Given this list of marker genes MTMR6, MFSD2A, ETF1, LINC00620, RCBTB2, WRN, SMAD9, SUB1, HASPIN, TNF, KCNJ10, GMNN, TMEM170A (transmembrane protein 170A), KCNQ3, AMOT, CNOT6L, OLFM1, ZNF366, RABL3, PTCHD3P1, SCUBE1, DMKN, RPS16P5, CDY1 (chromodomain Y-linked 1), SLC38A3, VSTM2A-OT1, C8orf34, PNPLA8, ZNF22-AS1, CASS4, PRDM5, DYNC2H1, BHLHE40, CXCL1, ZNF404, CREBRF, IL17D, IFNG, AEBP2, CDR1, CUL1, ZNF540, C15orf48, KIF16B (NCBI Gene Id 79757), FAM199X, ATG5, MN1, KPNA3, GABARAPL1, DCTN4, KRT76, TUBA1A, TBC1D15, MBIP, CFAP20, TEAD1, SNX4, TGIF2 (NCBI Gene Id 60436), ZBTB8A, CDH24, DDX51, RRP15, SLAIN1, WDR33 (WD repeat domain 33), FNDC8, CCKAR, AKAP9, BACE2, HSPA9, KIAA1586 (NCBI Gene Id 57691), ECSCR, RNASE3, ADRA2B, LRRC4B, MIR100HG, PDHX, SERPING1, ADGRB1, ZNF781, SELE, ASF1A, PRR22, PHLDA1, ENTPD1-AS1, ECE2, LINC00656, MEIG1, GPSM1, ARHGEF10L, PEG10, ESCO1, TOMM70, LPAL2, PSME4, RASGEF1B, OBP2B, NUDT11, EOLA2, FGF1, MNT, CAMK2A, TECRL, IFT20, WDFY1, KPNA5, CAPN14, YPEL5, PI3, EBLN2, UBQLN1, DTNB, LINC00226 (long intergenic non-protein coding RNA 226), ZNF292, ZNF569, CHORDC1, ZNF644, SPATA6L, PCDHB6, TFAM, ATP8A2, CCNF, NUP98, UBC, CAND2, CCNH, CCL20, THBD, CMSS1, PICART1, BCLAF1, CRY1, ZACN, KLHL34, MMP20, EREG, RNF38 (ring finger protein 38), TMEM9B, LRATD1, PPP2CA, SPAG6, CASD1, PROM1, KIAA0087, LAPTM4A, FBXO10, SPATA12, ROPN1, LYSMD3, DCAF4L1, PCDHB4, RBM15, TNFAIP6 (TNF alpha induced protein 6), CARMIL1, MYEF2, CEACAM8, MAP3K2, DUSP10, EEA1, VPS11, CRISP3 (NCBI Gene Id 10321), FBXO30, TNFRSF10C, APOM (NCBI Gene Id 55937), ANGPTL1, LIMK2, PSMB1, GALNT3, LRRC34, DBR1, WBP4, NDEL1, CYP4F3, NEFL, SNW1, NUDT13, CTNNB1, CAMP, MTERF4, PC, PIAS4, SEPTIN7P2, RIC3, ERVW-1, LINC00922, DIO2, CCDC43, TIMD4, LINC01354, SPMIP3, SPRY2, SMTNL1, here is a description of the gene set: studied in species Homo sapiens Human Gene Set: GSE29615_DAY3_VS_DAY7_LAIV_FLU_VACCINE_PBMC_DN Genes down-regulated in comparison of peripheral blood mononuclear cells (PBMC) from LAIV influenza vaccinee at day 3 post-vaccination versus those at day 7 post-vaccination. from publication Nakaya HI, Wrammert J, Lee EK, Racioppi L, Marie-Kunze S, Haining WN, Means AR, Kasturi SP, Khan N, Li GM, McCausland M, Kanchan V, Kokko KE, Li S, Elbein R, Mehta AK, Aderem A, Subbarao K, Ahmed R, Pulendran B (PMID 21743478) Systems vaccinology has emerged as an interdisciplinary field that combines systems wide measurements and network and predictive modeling applied to vaccinology. Here we used the systems vaccinology approach to study the molecular mechanisms underlying the innate responses to the trivalent inactivated influenza (TIV) and live attenuated influenza (LAIV) vaccination in humans, and to identify early gene signatures that predict the magnitude of the antibody responses to influenza vaccination.